Given this list of marker genes SCYL2, GPR137B, RASSF4, TECR, TMEM30B, ABHD4, PRKCD, RNF44, CD37, TFPI, NLRX1, PON2, ZNF319, VSIG10, PPM1L (protein phosphatase, Mg2+/Mn2+ dependent 1L), NFKB2, GSTT2, ITPKC (inositol-trisphosphate 3-kinase C), BAIAP3, ADIPOR2 (NCBI Gene Id 84751), HPS6, CYB561D2, MT1E, GIMAP8, SPCS2, HEXIM2, GNPNAT1, FOXN3, PDP1, TRAF5, SPCS1, YIF1B, BCL2L2, DBI, PRRC2B, SULT2B1, JUNB, LZTR1 (leucine zipper like post translational regulator 1), MAP2, FAM216A, ZC3H12D, CASP7, FDX1 (NCBI Gene Id 2230), TMBIM4, WDR82, NUP155, MYO1C, IL12RB1, UEVLD, IL1RN, KHDRBS1, PTK2B, ECI1, SLC52A3, ISOC1, KANSL1L, NAA10 (N-alpha-acetyltransferase 10, NatA catalytic subunit), ITGB1BP1, ZC4H2, ZNF264 (zinc finger protein 264), TYMS, TK1 (thymidine kinase 1), CHAF1B, ATP13A2, SEM1, FBXW8, CSTB, TMCC1, LPIN2, PMM1, ORC5, STK40, PPIA, HK1, C11orf68, IMMP2L, CAPN3, MLKL, SQSTM1, SPTBN4, CYSLTR2, MCUB, PIK3R3, CCR1, TNFAIP8L1, RPIA, NAA60, GABARAPL1, AK3, DNAJB14, LIMK2, RIN3, PYCARD, GGT7, PITPNM1 (NCBI Gene Id 9600), DYNLT5, PPP1R15A, RAB11A, NCF4, ST7L, SLC43A2, PRXL2C, ITPRIPL2, SPOCK2, FDFT1 (NCBI Gene Id 2222), ZBTB17, EHHADH, ASB3, CREBBP, IL27RA, IFRD1, EIF5A, TMEM42, PNRC1, PFN2, IRF6, IPO5, SLC39A10, PARP4, GTDC1, ZDHHC15, THBS1, SERPINI1, CIP2A, SLC22A15, PICALM, CDKN1C, CPQ, GALM, MGAT5 (alpha-1,6-mannosylglycoprotein 6-beta-N-acetylglucosaminyltransferase), C3orf70, PTCD1, PWWP2B, GPR150, DKK3, SBNO2, SCAMP2, CRTC3, RAP1B, AMDHD1, DCXR, CTDSP2, USP42, PIGC, RNF128, VGLL4, TUG1, NDFIP2, NAB2, ARHGAP25, MT2A, IFT22, EDF1 (endothelial differentiation related factor 1), PABPC1L, PKP2, STN1, SEC24D, GSE1, DRAM1, AZIN1, FZD2, FKRP, AP3B1, TAC1, CXCL11, CYB5D2, NRDC, SPRY1, RDH16 (NCBI Gene Id 8608), WWP1, RFX1, RNPEP, CD72, CLDN12, GRIK5, IL13RA1, ARL3, DOCK2, TSPOAP1, XRCC3, ASPM, RBFA (ribosome binding factor A), MID1IP1, MAP7D1, GOLGA7, HMGCR, NRROS, PSMA4, LMO7, PHGDH, FUCA1, TRIM24, MSL3, MAP1LC3B, ZBTB24, RBM45 (RNA binding motif protein 45), CTNNA1, HLA-B, CREBL2, here is a description of the gene set: Genes up-regulated in dendritic cells with knockout of NLRP10: control versus LPS. Nlrp10-deficient mice have a profound defect in helper T cell-driven immune responses. T cell priming is impaired due to a defect in the emigration of a dendritic cells from inflamed tissue and antigen transport to draining lymph nodes. DC chemotaxis to CCR7-dependent and independent ligands is intact in the absence of Nlrp10. Therefore to identify novel molecules potentially involved in Nlrp10-dependent DC function we used an unbiased gene array approach on Nlrp10-deficient BMDCs treated with or without LPS. Human Gene Set: GSE36009_UNSTIM_VS_LPS_STIM_NLRP10_KO_DC_UP studied in species Homo sapiens from publication Eisenbarth SC, Williams A, Colegio OR, Meng H, Strowig T, Rongvaux A, Henao-Mejia J, Thaiss CA, Joly S, Gonzalez DG, Xu L, Zenewicz LA, Haberman AM, Elinav E, Kleinstein SH, Sutterwala FS, Flavell RA (PMID 22538615)